The following is a description of a gene set: studied in species Mus musculus Any process that modulates the frequency, rate or extent of the regulated release of mucus from a cell or a tissue. Mouse Gene Set: GOBP_REGULATION_OF_MUCUS_SECRETION, and this is the list of marker genes: Ptger4, Nlrp6, Cyba, Sytl2 (synaptotagmin-like 2), Alox12b, Atg5 (NCBI Gene Id 97669), Egfr, P2ry2, Adora3, Prkce, Ada, Atg7, Map1lc3b, Adora1